Given this list of marker genes Wwox, Pik3ca, Cdkn2a, Wif1, Apc, Smarca4, Prdx1, Nf2 (NCBI Gene Id 18016), Prkar1a, Msh2, Sav1, Trp53, Mad1l1, here is a description of the gene set: Mouse Gene Set: MP_INCREASED_OSTEOSARCOMA_INCIDENCE from publication Motenko H, Neuhauser SB, O'Keefe M, Richardson JE (PMID 26092688) studied in species Mus musculus Mouse genes annotated to increased osteosarcoma incidence (MP:0003789) retrieved from the Mouse Genome Informatics database via MouseMine